Given this list of marker genes Dhrs1, Gngt2, Abhd17a (NCBI Gene Id 76403), Igkc, Lyz2, Nostrin, Ftl1, Tep1, Rgs10, Cox7a2l, Comt, Rxra, Calhm6, Rsrp1 (NCBI Gene Id 72409), Ncoa4, Vamp5, Mrpl42, Aif1, Erp29, Abi3, Rxrg, Crip1, Epsti1, Ubb, Hpgd, Tmem256, here is a description of the gene set: from publication Cui A, Huang T, Li S, Ma A, Pérez JL, Sander C, Keskin DB, Wu CJ, Fraenkel E, Hacohen N (PMID 38057668) Cytokines mediate cell-cell communication in the immune system and represent important therapeutic targets. A myriad of studies have highlighted their central role in immune function, yet we lack a global view of the cellular responses of each immune cell type to each cytokine. To address this gap, the authors created the Immune Dictionary, a compendium of single-cell transcriptomic profiles of more than 17 immune cell types in response to each of 86 cytokines (>1,400 cytokine-cell type combinations) in mouse lymph nodes in vivo. A cytokine-centric view of the dictionary revealed that most cytokines induce highly cell-type-specific responses. For example, the inflammatory cytokine interleukin-1β induces distinct gene programmes in almost every cell type. A cell-type-centric view of the dictionary identified more than 66 cytokine-driven cellular polarization states across immune cell types, including previously uncharacterized states such as an interleukin-18-induced polyfunctional natural killer cell state. Genes negatively differentially expressed in cell type: Macrophage upon treatment with cytokine: IL-1α in mouse lymph nodes in vivo. studied in species Mus musculus Mouse Gene Set: CUI_MACROPHAGE_IL1A_RESPONSE_DN